The following is a description of a gene set: Human Gene Set: GOBP_CHEMICAL_HOMEOSTASIS species: Homo sapiens Any biological process involved in the maintenance of an internal steady state of a chemical., and this is the list of marker genes: UBE3A, ETNPPL, SCTR, TMEM175, ZBED6, KCNJ2, TLCD3A, ATP13A4, SOAT2, TRPM4, USF2, DHPS, ATP7B, SLC17A6, STEAP4, ADORA1, ATP6V1G1, FTL, RHCE, CCL1, RYR2, DRD5, CNNM2, HYAL2, DMPK, TMCO1, PHPT1, ABCA5, AKAP11, HRC, CLIC2, SLC45A2, GAS6, CLN8, MCOLN1, EFNA5, SLC25A46, CETP, TPT1, SURF4, SLC8A3, SLC12A7, PTCH1, LIME1, TRIM24, IL6, HAS2 (NCBI Gene Id 3037), NCOA5, ORMDL2, FBXL5, ORMDL3, CCL14, FBN2, DIAPH1, PNPLA3, HNF1A, IGF1R, NR1H3, ATP4A, OBP2A, OSBPL8, SELENOT, TMEM165, USF1, SCARB1, SCN7A, SLC4A8, PLCE1, ITGB6 (NCBI Gene Id 3694), SCNN1G, STIM1, MIR320D2, GRINA, KCNA5, GCM2, FOXK2, PRND, SLC39A12, CALB2, RORA, BAD, GPER1, ATP12A, COMMD9, ABCA1 (ATP binding cassette subfamily A member 1), SPX, CCDC186, PDX1, PLN, MLLT6, SGCD, RNASEK, ANK2, SLC39A7, CRY1, PRNP, ADGRF5, SIDT2, GRID2IP, F2RL3 (NCBI Gene Id 9002), PNLIP (NCBI Gene Id 5406), ATP13A2, VAPB, SLC34A3, ABCG5, SPPL2C, STAT3, CALM2, FTH1, GDF2, BDKRB1, MICU2, PRKCB, AGER, SIN3A, PRKAA2, CASR, MIR15A, POLD1, SOD2, GPAM, CAV1, NT5E, ADNP, LPL, TLCD4, PNLIPRP1, MALL, ERC2, LRRK2, PNLIPRP2, MT1B, HIF1A, PDE4D, SLC1A3, SLC26A3, GP9, ATP6V1D, TRPM8, PDK4 (pyruvate dehydrogenase kinase 4), TF, ENPP3, SLC25A23, GLRX3, CLN5, CCL5, OTC, RAB7A, APOC3, MT1G, POU3F3, ABCC8, GRAMD1B, MT1E, TRPM7, IRS1, GOT1, CCL11, TNFSF11, APLNR, ANO1, DGAT1, ATP1A3, XK, SMAD3, LRRC8A, NCF1, PDZD8, APOA1, SLC12A3, FITM2, FECH, SLC16A1, ERO1B, STIM2, UMOD (uromodulin), FUT1, KCNA1, DDX3X, ERRFI1 (ERBB receptor feedback inhibitor 1), PIK3CB, ATOX1, TMEM38B, CNNM1, SLC12A8, CXCL10, VEGFA, PRKAA1, LPCAT1, PTPRN2, TMPRSS3, TMEM174, GSTP1, HCRTR1, AGT, MIR144, CYP39A1, ABCB4, FKBP1B, SCT, CALCB (calcitonin related polypeptide beta), RAB39A, SLC12A9, NEO1, HNF4A, ATP5F1B, ABCD1, SEC24A, CMA1, RBM4, ATP1B1, ABCG1, AKAP6, MT1M, GJB6, SFRP4, PDPK1, INSIG1, MAPK3, ATP4B, NR1H4, HKDC1, OPRK1, BMP6, IFNG, SLC30A2, GP5, TMBIM6, CES1, VGF, ATP1B2, SPNS1, WFS1, SMAD4, SLC39A8, MIR30C1, CYBRD1, PCSK9, IGFBP5, BACE2, CALB1, SLC26A6, CYP4F2, LAMTOR1, DMD, HEPHL1, FLNA, ITPR3, ADIPOR1, NGFR, MIR16-1, EPHX2, SLC34A1, MIR33A, PDE8B, ANK3, SLC4A11, SOAT1, SLC9A3, GCKR (glucokinase regulator), RAP1GDS1, STX4, ACOX1, RRAGA, MPC2, SLC2A2, RMI1, KCTD7, LIPA, CNNM4, ERN1 (endoplasmic reticulum to nucleus signaling 1), CYBA, SLC46A1, LEPR, FGFR1, EIF2AK1, CYP7B1, EDN1, GCLC, SLC40A1, FOXA2, ADRA2A, GLS, ITPR2, TSC22D4, HERPUD1, G6PC2, SLC31A2, HTR2B, ZBTB20, CDK16, SYPL2, IBTK, SCNN1B, GRM5, SLC12A2, CCL7 (NCBI Gene Id 6354), ATP2B4, SESN2, PIK3R1, GHITM, DBNDD2, THADA, RAB11FIP5, APOB, WNK3, SMAD9 (NCBI Gene Id 4093), NR1D2, RYR3, ABHD8, EDN3, TBXAS1, FOXA1, FAM3A, DISC1, SIRT1, CYB561A3, MIR337, PRKACB, DGAT2, IER3IP1, ANGPTL8, CNNM3, SLC10A7, SLC9A1, TMEM94, P2RY6, AVP, OAS1, MICU3, CLDN16, MYH7B, TMTC4, CCDC47, DRD3, TPCN2, MIR133A1, ABL1, BOLA2B, RACK1, ACSM2A, ALPL, PSEN1, SLC22A17, VSNL1, CCL13, NPY, INSR, SELENOK, APOC4, GHRHR, BTBD9, PLSCR3, COMT, MIR320C1, PCK1, RPS6, CHP1, FAM20A, NGF, BRSK2, PAX2, FXN, PRKACG, EPHA5, SLC4A1, PRKN, SLC30A9, PLCL2, GPX1, KEL, C1QTNF3, CD19, CCR1, ZNHIT1, GCLM, SRI, NKIRAS1, CA12, NPR1, C2CD2L, ENPP1, AKT1, SAR1B, CACNA1S, MIR320B1, SLC24A2, MECR, GRN (granulin precursor), PRKD1, NPC1L1, IL18, TRPC7, OCA2, NUBP1, CXCL11, C1QTNF12, SMARCB1, PDK2, MINPP1, COL1A1, CHRNA7, XPR1, HPX, CHERP, FOXA3, ATP6V1F, ITPR1, JPH2, SLC24A5 (solute carrier family 24 member 5), MED13, MICU1, MIR210, EDNRA, PLCH2, PAX6, HTT, SLC4A9 (NCBI Gene Id 83697), ATP13A1, CIAO3, NR1H2, PRKCE, PIK3R2, NOX4 (NCBI Gene Id 50507), TMC8, CMKLR2, MTLN, WNK2, CCR2 (NCBI Gene Id 90262), MIR19B1, MYC, PRCP, PLA2G6, ABCB6, BGLAP, NAGLU, HSDL2, GATA4, MIR34A, ABCG4, XBP1, MTTP, RFX6, SLC39A10, ATP6V0A1, PLA2G12B, ATP6V0E2, STOML2, NADK, XCR1, MIR320A, PPP1R3G, ATP1A1, NAPSA, CACNB2, ARF1, PTH1R (NCBI Gene Id 5745), TENT4B, LCN6, OR10J5, FGF2, EPB42, SLC30A5, SREBF2, AQP1, CRH, ATP13A3, ACVR2B, OXCT1, KLF15, WBP2NL (NCBI Gene Id 164684), IGF1, BNIP3, CCR7, SOD1, MALRD1, EXT1, PFKM, SLC30A1, PTPN2, KLHL3, SLC24A3, ATG5, TMEM106B, BAX, IL1A, KCNE3, GSTO1, HK1, SCNN1D, NPTN, SV2B, ATP6V0B, GHRL, RHCG, NNT, MAPK1, FRRS1, SLC31A1, ICAM1, LDAH, AQP3, KL, LETMD1, AGTR1, PTPRN (protein tyrosine phosphatase receptor type N), TFR2, SLC4A3, GPR12, HMOX1, MYLIP, BECN2, FASLG (NCBI Gene Id 356), ANGPTL3, PNPLA1 (patatin like phospholipase domain containing 1), ATP2A1, FXYD2, BAK1, PLCB2, JPH3, SLC26A4, RAB30, NDUFAF2, MIR33B, GPIHBP1, MAIP1, GLRX5, CIB3, DMXL1, TGM2, ATP1B3, PYGL, APOA4, SSTR5, NPC1, SLC8A2, RBP1, TRDN, RAB11B, CARTPT, CCL21, GPR68, SNCA, LDLR, GPLD1, SLC24A1, BAIAP3, ROGDI, ORMDL1, TMEM63A, WDTC1, SLC12A5, FOXK1, APOC1, NPPB, SLC39A5, CNR1, IL13, TRPV4, ACACB, COMMD1, NUS1, ABCB11, NPSR1, P2RY2, TMEM203, SLC30A10, DRD2, OSBPL2, HECTD4, PTH, S100A14, MCUR1, ADIPOQ, ANGPTL4, MUSTN1, ACSM3, JAGN1, SLC9A9, FOSL2, PARK7, FOXO3, FBN1, NPTX1, MIR1-1, HJV, SLC11A1, TLCD1, METTL21C, ABCC6, NFE2L1, RAF1, CTRC, SCO2, YWHAE, MIRLET7G, GPR89A, TRPC4, KAT5, POMC, NR5A2, DHRS7C, TMPRSS6, TMEM38A, TGFB1, CNBP, STC1, KCNJ10, FOXO1, LAMP1, PPP3CB, TSPOAP1, MCUB, PPARG, ATP7A, BOLA1, KCNB1, SLC39A6, CTSH, CORIN, CRY2, TMEM97, PICALM, CFTR, KCNMA1, STK39, SLC25A27, TREM2, TMEM64, PTPN6, FABP3, PPARD, ADCY8, CPS1, SLC12A6, DISP3, LCAT (lecithin-cholesterol acyltransferase), GSTM2, APOA2, CCN4, CALM3 (NCBI Gene Id 808), SLC9A2, BLOC1S6, KLF7, HK2, CXCR3, ATP2B3, MIR208A, ASPH, CSMD1, HAP1, TRPV6, EHD1, TRPM5, NPC2, WNT5A, STXBP4, SLC8B1, ACACA, HLA-DRB1 (NCBI Gene Id 730415), GCK, CDH5, CA7, CISD1, MT3, GCGR, DBH, COX10, CCR5, CX3CL1, NCOA4, DRD1, FBXW7, ATP6V0C, KDR, THY1, SLC37A4, TLCD3B, DYNLL1, SLC9C2, SLC9A8, NKIRAS2, BCL2, PKD2, AFG3L2, MT1A, FSHR, CLCN3, SLC4A7, HDAC9, RBP4, ATP6V0E1, ZNF236, ADCY5, CASQ2, ATP6V1H, ENDOG, ATP6V1A, SCNN1A, LETM1, ABCG8 (ATP binding cassette subfamily G member 8), NDFIP1, MBD5, FKBP1A, SLC12A4, F2R, PRKACA, ENPP7, TPP2, PIM3, AMPD2, ACSM1, LCN2, SLC9A5, APP, CYP4A11, UNC80, CEMIP, LYN, SLC41A1, ASPSCR1, CCL8, EGLN1, CYP11B2 (cytochrome P450 family 11 subfamily B member 2), SESN3, SLC38A3, TMTC2, SYBU, SLC9B1, AQP2, INS, MIR27B, LRRC8D, CASQ1, MLXIPL, CLTRN, TCF7L2, ATP1A2, FGF23, SMARCA4, CAPN3, SLC9A6, SLC1A1, ATP6V0D2, UBASH3B, FFAR2, NUCKS1, SLC9B2, CCL3 (C-C motif chemokine ligand 3), IMMT (NCBI Gene Id 10989), TMC6, PLA2G10, WNK1, PNPLA8, P2RX7 (purinergic receptor P2X 7), SLC39A14, F2, AQP6, CAV3, CLN3, CYP27B1, ABHD4, GRM2, GPRC6A, RCN3, BPIFA1, MIR93, CCL15, FUNDC2, PSEN2, TRPC3, CA2, PKHD1, MT1H, AVPR1A, SLC4A5, ADISSP, PML, ADCK1, SLC4A4, ATP1A4, GPR21, SLC9A4, CREG1, SMAD1, CYP4F12, ISCU (NCBI Gene Id 91850), CYP11B1, EDNRB, SLC30A7, CEBPA, CCDC115, AKR1C1, SIRT6, WNT7B, BHLHA15, ATP2B2 (NCBI Gene Id 491), MT2A, GP1BA, MIR302A, PTPRC, FABP4, PIH1D1, LGSN, ERFE, SLC12A1, LACC1, LEP, MIR379, TRPC6, FLVCR1, CACNA1C, SOX4, APOE, ATF4, GRM1, UCP2, HEPH, AKR1B1, OSBPL11, RPTOR, TRPM2, ALAS2, MC3R, GNAS, MIR320D1, SCO1, ABCB7, CLN6, TMEM199, SNX10, TMEM63B, GP1BB, CCL19, ATP6V0A2, GPR27, SLC9A7, VDR, CD24 (NCBI Gene Id 934), KCNH2, SUCNR1, STC2, SLC8A1, MBL2, TUNAR, SLC39A9, ADCY6, OGT, ACO1, GCG, NTSR1, PNPLA2, SLC4A2, HEXB, SLC30A8, CALM1, RAC1, CHD7, TTC39B, COX11, HFE, GRIK2, CRTC2, SRF, CXCL12, PLCB4, PACS2, MIR320E, SLC17A8, HTR2C, TM9SF4, CDH23, VPS54, B2M, P2RX1, HVCN1, ATP13A5 (NCBI Gene Id 344905), FTH1P19, PLCG1, SLC66A1, ATP6V0D1, ATP6AP2 (NCBI Gene Id 95880), CERT1, CCDC22, MIR148A, SLC39A4, G6PC1, MAP2K1, RTN4, TM6SF2 (NCBI Gene Id 53345), MTNR1B, CYB561D2, PTPRJ, MYO5B, KCNK16, SGCB, XCL1, CCL23, TRA2B, LACRT, FATE1, TNNI3, SLAMF8, MT4, AQP11, NEGR1, FZD9, ABCA3, RHD, CIB2, PTPN11, MINAR2, PNPLA4, GUCA2B, NR1D1 (NCBI Gene Id 9572), INPP5K, ATP2C2, MTCH2, PIK3CA, FIS1, ATP6V1B1, TMEM178A, UNC13B, SMAD5, PTK2B (protein tyrosine kinase 2 beta), JPH4, CYP7A1, AP3B1, MIR185, FFAR1, CAMK2D, TRPC5, ATP6AP1, FTHL17, ATP2C1, MIR590, CLCC1, CALCA, BOLA2 (NCBI Gene Id 552900), CUTC, ATP2B1 (ATPase plasma membrane Ca2+ transporting 1), SNAPIN, SERPINF1, MT1F, SMDT1, TCIRG1, CD40, ATP2A3, ANXA6, TLCD2, HAMP, LIPG, CORO1A, SLC35G1, CACNB4, TESMIN, TTC7A (tetratricopeptide repeat domain 7A), HPS6 (HPS6 biogenesis of lysosomal organelles complex 2 subunit 3), TASL, LAMP2 (NCBI Gene Id 3920), STK11, STEAP2, TMEM9, MT1HL1, TSKU, MIR146A, CAV2 (NCBI Gene Id 858), FGFR4, UPK3A, CYB561, ITGB3, IREB2, MIR182, PNLIPRP3, ANKRD9, OSBP, BOK, ADIPOR2, SLC34A2, PLCL1, RPH3AL (NCBI Gene Id 9501), RGN, SELENON, DMXL2, HCRTR2, LDLRAP1, DMTN, GRIN1, ATP6V1B2, SLC29A1, SLC11A2, TRPV5, MT1DP, RHAG (Rh associated glycoprotein), HK3, FTMT, EXT2, HTR2A, MIR128-1, MT1X, LIN28A (NCBI Gene Id 79727), MIR320B2, COX19, XIAP, PLCB1, ALOX5, ASL, P2RY1, RAB11FIP2, RMDN3, SLC2A4, PPARGC1A, BOLA3, SLC39A13 (solute carrier family 39 member 13), ANKH, NKX6-1, SLC24A4, CNGB1, GPI, HSP90B1, ABHD5, DRD4, DUSP29, RALY, PNPLA5, ATP2A2, IRS2, TRPC1, SLC4A10, SFTPD, PPT1, LCK, RAB38, CDKN2A, EPAS1, WNK4, PCK2, ABCA12, ENY2, PLCB3, C19orf12, APOC2, CP, CCKBR, CXCL9 (NCBI Gene Id 4283), AQP4, ATP6V0A4, MCU, CYB5R4, SLC7A11, LIMA1, SLC9C1, MIR320C2, TSPO, APOA5, NHERF1, ERO1A, APPL2, CLIC4, NPPC, FABP5, EDN2, MIR132, SV2A, RAB20, GPR89B, LIPC, LRP5, VPS33A, DDIT3, JPH1, CALR (calreticulin), ABCA2, APOM, STXBP3, SLC17A7, GLUL, UBTF, RHBG, NOL3, KCTD17, SCARA5, MIR103A1, ELANE, PLCG2, CSRP3, KCNQ1, TFRC, NEUROD1, PLCH1, RYR1, TRPA1